The following is a description of a gene set: Mouse Gene Set: TABULA_MURIS_SENIS_KIDNEY_FIBROBLAST_AGEING studied in species Mus musculus from publication Tabula Muris Consortium (PMID 32669714), and this is the list of marker genes: Rpl12, Rps26, Rpl23, Rpl39, Rps18, Rps16, C1s1, C3, Rpl18a, Rps15 (ribosomal protein S15), Rpl22, Rpl13, Rps28, Rps15a, C4b, Rps10, Rpl37, Rps19, Fbln2, Rps27a (NCBI Gene Id 78294), Rps15a-ps6, Rps13, Rps23, Rpl21, Rps4x, Rpl31-ps12, Rps9, Rps5, Rpl8, Rpl27, Rps17, AW112010, Rps3, Rpl32, Rpl6, Ly6a, Rps25, Eef1b2